Given this list of marker genes Mgam, Amy2a4, Chit1, Chia1, Amy2a2, Lct, Amy2a5, Sis, Amy2a3, here is a description of the gene set: Mouse Gene Set: REACTOME_DIGESTION_OF_DIETARY_CARBOHYDRATE Digestion of dietary carbohydrate species: Mus musculus